Given this list of marker genes UBA52, RSPO3, UBC, RSPO2, WNT3A, RPS27A, LGR5, USP8, RSPO4, UBB, FZD6, LRP6, RSPO1, LRP5, FZD4, LGR6, FZD5, RNF43, ZNRF3, LGR4, FZD8, here is a description of the gene set: Reactome Pathway: Regulation of FZD by ubiquitination part of: TCF dependent signaling in response to WNT WNT responsiveness is influenced by expression levels of FZD and LRP proteins. Levels of these receptors at the cell surface are regulated in part by endocytosis, but the mechanisms are not fully elucidated. A number of recent studies have identified a role for ubiquitination in the localization and turnover of WNT receptors at the plasma membrane. ZNRF3 and RNF43 are E3 ligases that have been shown to ubiquitinate FZD proteins and promote their lysosomal degradation, while the deubiquitinating enzyme USP8 promotes recycling of the receptor back to the plasma membrane. This balance of ubiquitination and deubiquitination is in turn regulated by the R-spondin (RSPO) proteins, agonists of WNT signaling which appear to act by downregulating ZNRF3 and RNF43, thus potentiating both canonical and non-canonical pathways. species: Homo sapiens